Given this list of marker genes Gm5127, Dclk1, Map1b, Crppa (CDP-L-ribitol pyrophosphorylase A), Cask, Tmc3, Zrsr2, Tgds, Ifna12, Zfp1009, Agtr1b, Kctd12b, Armc8, Mid1 (NCBI Gene Id 637916), Gm5916 (NCBI Gene Id 639015), Crebl2, Ube2w, Klrb1a, Cfl2, Cpeb3, Trpm3 (transient receptor potential cation channel, subfamily M, member 3, NCBI Gene Id 435591), Sorcs1, Pde3a, Asic2 (NCBI Gene Id 637557), Zfp326, Ube2d2a, Mga, Actc1, Cadm2, Bhmt, Gmip, Gje1, Atp11c (NCBI Gene Id 54668), Rpl37, Pkn2, Gm14325, Aldoart1, Mael, Irak2, Sla2, Baz1a, Cldnd1, Ifit3b, Gm14326, Rpl37rt, Zfp655, Hoxb13, Slc12a6, Acat3, Rai1, Sacm1l, Dsg2, here is a description of the gene set: Mouse Gene Set: MIR_468_3P studied in species Mus musculus Genes predicted to be targets of miRBase v22 microRNA mmu_miR_468_3p in miRDB v6.0 with MirTarget v4 prediction scores > 80 (high confidence targets). from publication Chen Y, Wang X (PMID 31504780)